Given this list of marker genes D7Ertd443e, App, Chfr, Ccnq, Birc5 (NCBI Gene Id 11799), Pinx1, Calm1, Orc1, Zfp830, Fhl1, Akap8, Aven, Hacd1, Smarcd3 (NCBI Gene Id 78383), Nes, Brca1, Rcc2, Clspn, Cdkn1a, Mbtps1, Rbbp8, Pkia, Donson, Mrnip, Etaa1, Macroh2a1, Zfyve19, Kcnh5, Ing4, Abcb1a, Syf2, Ccnb2, Rrm1, Cdk1, Plcb1, Brd4, Hus1, Ccny, Mastl, Fzr1, Nbn, Chek1, Pagr1a, Calm3, Usp22, Cdc14b, Cdc25c, Vps4b, Rad51c, Plk1, Mbtps2, Calm2, Cdc7, Ensa, Fbxo5, Cdk4, Vps4a, Pkmyt1, Trim39, Rad17, Fbxl7 (F-box and leucine-rich repeat protein 7), Ctc1, Rnaseh2b, Akap8l, Taok1, Arpp19, Ube2a, Npm1, Cdk2, Pbx1, Ppm1d, Dyrk3, Pdik1l, Foxn3, Cdk6, Kif14, Usp50, Nek10, Ndc80, Aurkb, Hus1b, Dtl, Gpr132, Brsk2, Creb3l1, Babam2 (BRISC and BRCA1 A complex member 2), Nabp2, Rab11a, Nop53, Fbxl15, Atf5, Bard1, Taok3, Paxip1, Pabir1, Stox1, Ier3, Ticrr, Cdk5rap3, Cenpf, Chmp4c, Hspa2, Ccna2, Topbp1, Mre11a, Trp53, Taok2, Chek2, Uimc1, Ccng1, Cdk10, Kat14, Ints3, Abcb1b (NCBI Gene Id 18669), Ccnb1, Inip, Atm, Skp2, Babam1, Sin3a, Cdk14, Stk35, Cdk3 (NCBI Gene Id 69681), Cdc6, Kdm8, Mta3, Nabp1, Foxo4, Cit, Lmnb1, Tpd52l1, Cdc25b, Rint1, Prkcq, Ccnb1-ps (NCBI Gene Id 672788), Atr (NCBI Gene Id 382093), Ush1c, Wee1, Rad51b, Brcc3dc, Usp47, Abraxas1, Ccnd1, Brsk1, Foxm1, Nae1, Taf2, Atad5, Miip, Mbd4, Ccdc57, Brcc3, Lats1, Cdc25a, Rad50, Rrm2b, Dbx2, Wnt10b, Rad21, Camk2d, Usp17le, Blm, here is a description of the gene set: The cell cycle process by which a cell in G2 phase commits to M phase. species: Mus musculus Mouse Gene Set: GOBP_CELL_CYCLE_G2_M_PHASE_TRANSITION